Given this list of marker genes EIF4G3, CDC42EP2, TALDO1, SP100, MARCKS, PSME1, ABCC5, RARRES1, YBX3, IRF2, PLEK, ZNF473, MVD, PTPRG, CTSH, PECAM1, NRDC, ZFYVE21, PRMT5, SECTM1, RTN3, SYT12, OGFRL1, ATF3, TMEM132A, APOBEC3A, LAT2, MCL1, SH3D21 (SH3 domain containing 21), CPPED1, RUBCNL, BAZ1A, STEAP4, IFITM3, UCP1, BAD, MME, FOS, HEBP1, AGPAT1, FBXL5, LILRB2, CLEC11A, BLTP3B, TRIB1, B4GALT1, HSD17B11, KIAA0040, CERNA1, INTS8, MOSPD2, KRT32, ERBB2, SPTLC2, ICAM1, SNRK, TNFSF10, POLR1G, GNG5, FTH1P5, STX10, DYSF, SPTBN4, ZYX, CXCL14, VIM, REPS2, BPGM, WDR26 (WD repeat domain 26), NRBF2, SP3P, CYTH4, OSBPL8, GNAQ, ZNF107, IL1RN, ZFAND3, CSF3R, S100A12, H2BC4, EIF4EBP2, DUSP22, RPS6KA1, DENND5A, UBE4B, MAP3K3, CNPY3, OR10H2, AGMAT, FLOT2, RESF1, APOLD1, NACC2, YIPF1, TNFRSF10C, PRUNE1, PITPNA, MSL1, VPS37B, FAM53C (family with sequence similarity 53 member C), NAA50, SIGLEC5, PF4V1, CTBS, PPM1F (NCBI Gene Id 9647), IFI35 (NCBI Gene Id 3430), CDA, RAB5IF, TNFRSF1A, SH3GLB1, CALML4, GPR87, STAT3, CNN2, ADM, SNN, STAT1, FCGR1A, GSK3B, KAZN, TMCC1, G6PC1, AKAP3, GBA1LP, TRIM8, LILRA1, DDX4, FAM163A, TCF7L2, CHD1, FEZ2, WWC3, UVRAG, KIAA0232, PPP2R5A, MGAM, OMG, HLA-B, PPM1E, CXCL6, TNNC2, LIPF, SF3A2, PGAP6, TKT, PTGES, MAB21L1, PRKCD, PFKFB3, DHX58, TNFAIP3, RAD9A, EIF1, EFHC2, NFIL3, MAP3K14, CEACAM1, MAP2K6, CDS2, PML, CWC25, CADPS, IL17A, HSD17B3, THRB, DUSP1, B4GALT5, TYMP, ORM1, KLRA1P, NPEPL1, CREB5, GSTK1 (NCBI Gene Id 51064), SLC48A1, FOLR2, IGF2R, EVI2A, LILRA3 (NCBI Gene Id 11026), SLC15A3, MFSD13A, DOCK4, SLC7A2, RAB20, TRAPPC8, TBL1X, GBP2, MAPK3, HNF4A, CASP5, JUNB, RAMP3, GARRE1, DPYD, MAST3, LTB, ACSL1, here is a description of the gene set: Genes down-regulated in comparison of eosinophils versus neutrophils. species: Homo sapiens from publication Jeffrey KL, Brummer T, Rolph MS, Liu SM, Callejas NA, Grumont RJ, Gillieron C, Mackay F, Grey S, Camps M, Rommel C, Gerondakis SD, Mackay CR (PMID 16474395) Human Gene Set: GSE3982_EOSINOPHIL_VS_NEUTROPHIL_DN In the present study we used Affymetrix oligonucleotide microarrays to produce gene transcription profiles for the major leukocyte types in humans. This comprehensive dataset enabled us to not only establish which genes were expressed in each leukocyte type, but also which genes were expressed in each subset after activation. The used of a comprehensive dataset of gene profiles from all the major human leukocyte subsets enabled a novel and powerful means for identification of genes associated with single leukocyte subsets, or different immune paradigms.